Given this list of marker genes CAV2, PRKAR2A, NOS3, BMPR2, PACSIN2, FXYD1, NEU3, CLN3, EHD2, LRRK2, LIPE, TNFRSF10A, KIF18A, CAVIN3, CDH15, CAV1, AKAP6, BVES, CDH13, CR1, CTNNB1, CORO1C, PTGIS, SKAP1, PLPP2, TFPI, CHRNA3, SLC2A1, MLC1, PRTN3, SCN5A, SPRED1, ATP1B1, HTR2A, F2R, SMPD2, TRPC4, HDAC6, MAL, BMPR1A, CD8A, KCNA5, CBL, EFNA5, ADD2, TEX101, NOS1, PLVAP, EZR, FASLG, DLC1, JAK2, FLOT2, TRPM8, SLC6A3, ADTRP, CHRNA7, MAPK3, MS4A4A, FLOT1, ADRA1B, PLPP1, EMP2, SLC22A6, SELE, SORBS1, ITGAM, INSR, GASK1A, KCND2, SRC, CD177, SCARB1, CAVIN4, HCK, ASAH2, ADCY8, STIM1, ATP1A2, IRS1, NOS1AP, ITGB2 (NCBI Gene Id 3689), CAV3, PRKAR1A, ADCYAP1R1, ENTPD1, CDH1, CD36, ATP2B4, CAVIN2, LCP2 (NCBI Gene Id 3937), MS4A1, LYPD4, TREM2, LRP8, HAS2, LRP6, MAPK1, PRKACA, ADRA1A, SMO, CHRNB2, DAG1, CAVIN1, LRP4 (NCBI Gene Id 4038), MYOF, MYO1A, CDH2, ORAI1, KCNMA1, SELPLG, RANGRF, CALHM1, TGFBR2, PTCH1, CTNNA1, here is a description of the gene set: A membrane raft that is part of the plasma membrane. Human Gene Set: GOCC_PLASMA_MEMBRANE_RAFT species: Homo sapiens